Given this list of marker genes CCDC138, SCN3A, WAC, YOD1, IPO7, ADAMTS6, SOX11, TDRD6, NAA30, ITGB1BP1, HCFC1R1, MACROD2 (NCBI Gene Id 284776), RUFY4, NEK1, RSPH4A, ACYP2, PLG, NEXMIF, MRS2, SOX2 (NCBI Gene Id 6657), BLTP3A, PCF11, TOMM22, MTCL3, MESD, FBXO32, STYX, NEK7, VAX2, PRDM11, FGF9, CFAP90, PPFIBP1, ZNF195, PDS5A, IPO9, GPATCH8, GCDH, TEK, SCN1A, TFB1M, BMPER, CNR1, ZNF75A, PIGX, SP3, NR1D2, COL15A1, NAV2, OLFML1, ANO6, CITED2, BCL7A, TOMM70, RPS6KA3, CREBRF, CEMIP2, CYP1A1, CDCA7L, GLI1, VIP, IDI1, HUS1, C1orf21, ZC3H12C, SH2B3, EVI2A, TRAF1, SNN, PRG4, FSD2, VTI1A, EPAS1, DSG1, DPY19L3, IGSF11, PAFAH1B1, EYA4, TRIM5, UBLCP1, ATP2B1, TNFSF15, ALG2, ELAPOR1, ZNF382, PPP1CB, MOB3B, LMNB1, RAB9B, APLNR, IBSP, QTRT2, ORAI3, MAPK10, SYT2, SIX4 (SIX homeobox 4), PLXDC2, SOS2, GABRA1, CAST, SLC17A2, NRP1, TAF1C, ITGB8, GRIK3, ADSS2, LIFR, PTPRG, NRIP3, CCN2, PAPOLA, ERCC6L2, ORC5, CPPED1, MGST1, TSR1, FGF12, MAP3K20, PADI2, BTG1, NREP, PDLIM1, ARHGDIB (Rho GDP dissociation inhibitor beta), METTL21A, PRDM10, ZEB2, FZD6, LIMD1, KCNIP4, CHD2, FADD, NPTN, FGFR2, RASSF3, TMEM229A, PHIP, MSI2, SLC7A14, EFR3A, CERS6, TMEFF1, COL10A1, here is a description of the gene set: from publication Chen Y, Wang X (PMID 31504780) Human Gene Set: MIR6733_3P studied in species Homo sapiens Genes predicted to be targets of miRBase v22 microRNA hsa-miR-6733-3p in miRDB v6.0 with MirTarget v4 prediction scores > 80 (high confidence targets).